Given this list of marker genes Slc25a12, Trp53, Cavin3, Actn3, Tigar, here is a description of the gene set: Any process that modulates the frequency, rate or extent of fermentation, the anaerobic enzymatic conversion of organic compounds, especially carbohydrates, to other compounds, especially to ethyl alcohol, resulting in energy in the form of adenosine triphosphate (ATP). Mouse Gene Set: GOBP_REGULATION_OF_FERMENTATION species: Mus musculus